The following is a description of a gene set: Any process that controls the length of actin filaments in a cell. Human Gene Set: GOBP_REGULATION_OF_ACTIN_FILAMENT_LENGTH studied in species Homo sapiens, and this is the list of marker genes: BAIAP2, CCL21, CTTN, CXCL12, CCL24, SPTA1, RICTOR, MTPN, ARHGAP35, CAPZA3 (capping actin protein of muscle Z-line subunit alpha 3), PREX1, PDXP, ALOX15, NPHS1, CCR7, ARPC3, RAC1, ARHGAP40, SPTBN2, DSTN, CARMIL2, CAPZA1, TMOD3, EVL, SNX9, CAPG, WASHC2C, PFN3, ARFGEF1, LMOD2, CSF3, CAPZA2, PLEKHG2, LATS1, PRKCE, CYFIP1, SPTBN1, LMOD1, ARPC5, PRKCD (NCBI Gene Id 5580), SVIL, CDC42EP4, MYADM, KANK4, KANK1, ARF6, CDC42EP3, ADD2, PFN2, ARHGAP28, BAG4, ACTN2, MKKS, CYRIA, SEMA5A, VASP, ARHGAP18, PFN1, SSH2, TWF2, TMOD2, BAIAP2L1, PTK2B, SSH3, TRIOBP, BRK1, CCL11, CRACD, DLG1, ARPC2, SH3BP1, TMOD1, ASB2, SLIT2, DAAM2, PLEK, ELN, CCL26, FER, ESAM, KIRREL1, RDX, HAX1, FCHSD2, SPECC1L, FCHSD1, TWF1, SPTAN1, COTL1, HCLS1, PYCARD, ABITRAM, C15orf62, HCK, BIN1, GRB2 (NCBI Gene Id 80715), WDR1, PAK3, NCK1, ADD1, MYO3B, NCKAP1L, AVIL, KANK3, F2RL1, CAPZB, PLEKHH2, SPTB, PIK3CA, KANK2, DMTN, ARPC5L, VILL, GSN, HIP1R, CARMIL1, CFL2, NEB, ADD3, LIMA1, SPTBN4, SPTBN5, PIK3R2, CDC42EP2, GBA2, EPS8, SWAP70, BBS4 (NCBI Gene Id 585), BAIAP2L2, NCK2, TMSB4X (thymosin beta 4 X-linked), MLST8, CORO1A, CFL1, SCIN, CYFIP2, MIR214, VIL1, NAA80, CDC42EP1, MTOR, TMOD4, RASA1, TMSB4Y, TENM1, CYRIB, SSH1, CDC42EP5, LMOD3, WAS, NCKAP1, MYO3A, FLII